Given this list of marker genes TGFB1 (transforming growth factor beta 1), SMAD2, ZFYVE9, TGFBR1, TGFBR2, SMAD3, SMAD4, here is a description of the gene set: Loss of Function of SMAD2/3 in Cancer Human Gene Set: REACTOME_LOSS_OF_FUNCTION_OF_SMAD2_3_IN_CANCER species: Homo sapiens